The following is a description of a gene set: Benign neoplasia derived from lipoblasts or lipocytes of white or brown fat. May be angiomatous or hibernomatous. studied in species Homo sapiens Lipoma Human Gene Set: HP_LIPOMA, and this is the list of marker genes: SMARCB1, AKT1, TBXT, COQ6, VANGL2, VANGL1, TAF1, TRAPPC14, PTEN, MAD1L1, NF1, ALX3, RPL10, KLLN, USF3, LZTR1, FUZ, CDC73, PIK3CA, SDHC, SDHB, APC, MNX1, SDHD, CCL2, FGFR1, MSTO1, NF2, SEC23B